Given this list of marker genes SNORD50B, NOP56, POLR1D, RIOX1, HNRNPL, MTERF1, DHX15, KCNC3, TSEN15, CCDC18-AS1, PARVG, RARS1, LINC00635, RPL13, NEAT1, TXNIP, TPM4 (tropomyosin 4), NSA2, PCLAF, ZC3H15, NUP155, MMADHC-DT, SPINT2, CKAP5, HCFC1, RIN1, HSPA8, DR1, ADAT2, LINC00663, CAPN7, UBE2K, SEMA4C, RACGAP1, HAGH, NOTCH1, ZNF25, GZF1, ZSCAN9, PECR, RNFT2, ZNF888-AS1, SYMPK, FBXO4, MAP1LC3B, ELOA-AS1, ADAM15, ZNHIT3, ZNF569, CAPRIN2, ST6GAL1, IGDCC4, HNRNPDL, LINC01719, ENSG00000233461, MAP3K5, CYTH1, HLA-DRA, DEPP1, SLC4A2, FAM167A, C3orf38, FRMD4A, MTRF1, POU2AF1, GAS1RR, ZBTB37, TBC1D19, MALAT1, OASL, PRKAR1A, MIR567, CDKN2D, PIH1D2, LINC01058, SLC3A2, KDM3B, DYNC2H1, APH1A, PPP1R15A, SNORD12C, RHOF, LMBR1, EHD1, RPL39L (ribosomal protein L39 like), EIF5A, MED16, WDR36, CD27, POLR3B, GPRC5B, EIF4ENIF1, GALNT16-AS1, BTG1-DT, ATF3, MBD6, NSFL1C, LY9, DCDC1, CRIPT, INPP4A (inositol polyphosphate-4-phosphatase type I A), ENSG00000282936, SLC30A6, ESYT1, CRK, RUNX3-AS1, CA11, GAPDH, UTP18, SH2D6, TTYH2, MPLKIP, SLC25A23, ENPP3, ARHGAP1, MTF1, NSD3, RBM8A, TMEM242-DT (TMEM242 divergent transcript), SNHG10, HLA-F, RUVBL1-AS1, LIMD2, IL10RB, TPI1P2, C12orf57, CDC42EP4, SLC1A4, PRORSD1P, NAA25, EWSR1, VPS51, ZRANB2-DT, RNF145 (NCBI Gene Id 353159), RPL7L1, HTATSF1P2, SLC37A2, EIF1AD, RNF41, BLK, PCBP2, IRF1, PELP1-DT, PLCXD1, GORASP1, DNAJC2, DIAPH1, NUP54, SLIRP, ADAP2, YIPF2, DLD, HIRA, MTOR (mechanistic target of rapamycin kinase, NCBI Gene Id 2476), TAS2R14, ZSWIM8, ITGB3BP, HSCB, B4GALT4, MTMR2, PPIP5K2, FBXO27, TCF7, TMEM114, CCDC28B, MSL2, TADA2A, CSPP1, KNSTRN, CALCRL, MON1B, MRPS18C, IGFLR1, KGD4, NDUFAF5, MIEF2, ARHGEF2-AS2, MBD1, KPNA6, GLRX, CAMLG, CENPU, KBTBD2, TMBIM1, TLE3, INPPL1, TENT2, ARTN, AFTPH-DT, CENPN-AS1, EGR3, IPO13, TRAF3IP3, GIN1, POLR2A, IMPDH2, SEC22B, MICU1, ITGA1, GTF3C2, BMS1P4-AGAP5, DNAJC24, IPO4, WIPF1, SLC35A3, ANAPC15, TRIP4, SNHG7, SRI, STIM2, MDP1, SLC35B1, TMBIM6, VPS13B-DT, DRG2, FLT3LG, MIR9-2HG, SNX5 (NCBI Gene Id 27131), ATN1 (NCBI Gene Id 1822, atrophin 1), DDIT3, NOSIP, RPS14, SUPT7L, RAPGEF3, CPSF2, PRH1, PARN, RUVBL1, PPP1R21-DT, CLUAP1, LIPE-AS1, LRP4 (LDL receptor related protein 4), ZNFX1, RPL18A, UBE2C, TMEM167B, ARPC5, PTDSS1, PRRG2, ZNF574, ERF, CDK1, SBDS, ZMYM1 (NCBI Gene Id 79830), LINC01275, MIR4434, RBM5, BMS1P4, RPS21-DT, GFM2, DNM2, RNU6-9, LOXL3, SLC2A4 (NCBI Gene Id 6517), LIX1L, SNORD110, ITGA5, CD8A, LYRM1, ZCWPW1, PPP1R21, UQCR11, CXCR4, PNRC2, MYL5, PCNX4-DT, MCEE, ELMO1, SIDT2, MIR638, TRPV2, VPS25, PLEKHG1, ZSCAN16, LSG1, WDPCP, RNA5SP60, BABAM2, NCAPD2, ZFAS1, KCNIP2-AS1 (NCBI Gene Id 100289509), AP4E1, DHX33-DT, TMEM70, GLUD1P3, BCL9L, DGKH, GSTCD, ANKRD34A, TCEA1, TRIM33, POLR1HASP, HOXB5, KLF7, PELP1, SSBP1, MAST3-AS1, TSC22D4, FIS1, NME1, VEGFA, EMC10, CXXC5, IRF2BP1, PLCG2, IGHMBP2, IL10RB-DT, AGRN, MIR6853, ZBTB40, MUS81, MLLT6, KDM4C, FHIP1B, DAPP1, DUS1L, NAA16, KDM2A, SBDSP1, DCUN1D3, IRF9, C1RL, GLIPR1L2, SMG7, ZFP36L1, ANKRD40, PTRH1 (peptidyl-tRNA hydrolase 1 homolog), LY75-CD302, SKIL, ARHGDIA, KDM1A, TMEM230, BRD1, PKIG, TACO1, JUN-DT, STX18-AS1, NUP205, MPHOSPH10, CENPA (NCBI Gene Id 1058), NDUFV1-DT, WDSUB1, SCAP, NUMA1, TMEM14B-DT, BCL2A1, PLXNC1, SIAH1, ENSG00000272008, ZNF331, CCDC144BP, TPT1, SLC44A1 (NCBI Gene Id 63942), PREX1, HAVCR2, SRGAP1, INVS, RNF185, CD86, SNORD35B (NCBI Gene Id 84563), FBXO31, ETFB, CENPT, CCNC, CHD8, AKAP8L, SAMD12-AS1, FUS, TRAK2, BUB1, LTA4H, ZNF425, U2AF2, CLPB, MIR6815, SPRING1, IQCH-AS1, RHOT2, EIF5, PCNX4, SUV39H2, EIF4A1, TOP1, ATMIN, ZFP36, FANCI, SH3BGRL3, NPLOC4, UGGT1, DNAJC25, FBXO34, GRK2, MRPS31P5, GPR156, VPS26B, GNA13, FLYWCH2, TBC1D4, CLTC, NCBP2, OSGEPL1-AS1, JMJD1C, CDKN1B (NCBI Gene Id 1027), TCF4, COA6-AS1, CLK3, KBTBD4, UQCC6, PSMD3, TMEM41B, CHEK2, TMEM187, TLN1, MED15, C1orf54, FBXO28, ZNF408, RANBP2, PTPN11, CPOX, SMARCD2, SLC25A3, IGLV2-5, ICAM1, ZDHHC20, HDAC11, KIAA1671, ATP13A4, ZNF581, BNIP1, BRF2, C2orf92, RBM17, GATC, TOR1AIP1, NCOR1, MIR181A1HG, PBRM1, UBE2I, SMARCA2 (NCBI Gene Id 95083), SMC3, ATG4B, PRR4, IRF2BP2, NPM1, NDUFAF1, DNAJC25-GNG10, FXR1, SATB2 (SATB homeobox 2), ESS2, THUMPD3-AS1, EOGT, POFUT1, GAS1, THOC7, GEMIN5, H3-3B, UBE2L3, CDK6-AS1, QRICH1, GHRHR, SAMM50, CDK11A, CARD19, FUBP1, IKZF4, YWHAG, PEX3, CPED1, RIPK3, POMGNT1, EDC4, STT3A, RUNX3, DUSP10, JUN, UROD (uroporphyrinogen decarboxylase), NOLC1, RRAGA, PUS10, PLAGL2, MIR5708, ALG3, MRPS33, ERI2, PET100, PHF5A, MTERF3, SAXO1, ARF4, FBXO38, EOGT-DT, HSP90AB1, AP4B1, GIHCG, POLD4, DDX18, NEU3, PARG, ZNF25-DT, NKAPD1, WDR74, RN7SL3, DHRS13, ENSG00000255240, H3-3A, ZNF384, RNU2-37P, TRMT5, EIF2S2, CHSY1, MRPL21 (mitochondrial ribosomal protein L21), TIMM29, ATP6V1G2-DDX39B, LY75, XPR1, SULT2B1, POLG, CDK5RAP1, MGC16275 (NCBI Gene Id 85001), RPS4X, LRRC37A5P, HEXIM1, STAT3, DPP8, RBM4, TPP1, CCDC117, SNORA71D, POLR1G, SF3B6, INO80B, MIDEAS, HIVEP1 (HIVEP zinc finger 1), MTMR9, BTN3A2, BRIX1, AAAS, FRA10AC1, TAGLN2, TAF8, TNIP2, RAB1B, GCA, DNAH7, BORCS8, VOPP1, HMGXB4, FAHD1, LDAH, GUCD1, TBC1D10B, FOXJ2, C18orf21, SH3YL1, GOLGA5, POLDIP3, HINT3, PPP2R3B, RGS5, LINC00265, OPA1, ENSG00000183154, EXD2, MED23, ZFYVE1, DHX33, TRUB2, TMEM101, RNA5SP283, BANF1, NFKBIL1, UBE2M, COIL, SEPTIN9, SCAI, TSR1 (NCBI Gene Id 55720), PLEKHB2, MRPS31P4, CDNF, RBM26-AS1, TRAF2, H4C4, BMS1, NR6A1, KIF18A, SNAP25-AS1, YJU2, STRADB, MIAT, DCLRE1B, CSK, ARL8B, ZDHHC2, ITGAL, MRPL16, DNAJB12, NPDC1, XPNPEP1, ZNF610, DNMT1, STK35, TNS2, DPY30, MIR4674, TNPO3, CDC73, GLRX5, IL6ST-DT, UBA7, B2M, UBE3B, RSRC1, CLIP2, SPON2, COQ4, CIB4, EIF3H, ZNF570, BAG6, ZNF580, ZC2HC1A (zinc finger C2HC-type containing 1A), P2RX5, TIMMDC1-DT, CXXC1, LMBR1L, SH3BP5, INO80B-WBP1, ATXN7L3-AS1, TRMT10C, SRPRA, CIITA, ZNF268, ECE1-AS1, R3HCC1, GOSR1, AIF1, ACACA, ANKRD39, DSTYK, GEMIN8, ABHD5, SYNE3-AS1, EML6, GNB2, ATG5, JMJD4, AGAP3, ING1, CFL1, TSPAN10, PDE6D, CALM1, ORMDL2, MBTD1, MRPL51, SGCA, DCP1A, FBXL3, LENG8, HDAC2-AS2, MRPS31, SH3BP1, NR1H2 (nuclear receptor subfamily 1 group H member 2), CHEK1, HSPA14, CCNJL, SLC35A2, SELENOH, EEF1A1P23, TFEB, ESF1, TIMMDC1, IDH2, STXBP1, ZNF827, IRF4, ENOPH1, ZNF165, GFM1, ZBBX, SERBP1, LINC01694, PPP1R3B, KMT2D, WDR83OS, MDH1, CAPS2, STX16 (syntaxin 16), LSR, WDR31, TLR1 (toll like receptor 1), NUP107, PPM1B-DT, SRSF11, PSMF1, TMEM175, ATP6V1G2, BRAF, RNVU1-6, CHIT1, THAP11, SNAP47, RN7SL521P, PATL2, ANK2 (NCBI Gene Id 4028), ZDHHC12-DT, NUP153, MKRN2, MIR17HG, GCC1, TIPARP, RNPC3-DT, MIR7845, ADRM1, SNHG17, RPRD1A (regulation of nuclear pre-mRNA domain containing 1A), AURKAIP1, ZNF20, RAB18, MFGE8, TCP11L2, RNVU1-31 (RNA, variant U1 small nuclear 31), CASP7, TNFRSF13C, RBM3, TATDN3, GTF2H4, MNAT1, ATP13A1, SLC33A1, SPAG8, CHD1L, VAPA, IFI16 (interferon gamma inducible protein 16), ZDHHC8, PIK3R2, TATDN2, YTHDC1, NCAPD3, ADISSP, MLH1, FAAP20, PDCD6-DT, RPS19BP1 (ribosomal protein S19 binding protein 1), FOCAD-AS1, NOL8, BTRC, RBKS, ATXN7L3, CUL2, DUSP11, NFKB2, STK17B, H2AZ1-DT, VPS9D1, EPM2A, KXD1, ENDOG, EEF1G, EEIG2, SLC27A5, MEPCE, RHBDD3, TUT1, CAPRIN1 (cell cycle associated protein 1), COPE, ADNP, EHMT2, KATNB1, PIK3R5-DT (PIK3R5 divergent transcript), DOK3, CD19, COL6A4P1 (collagen type VI alpha 4 pseudogene 1), CNBD2, HUWE1, POLG-DT, IFT56, MGME1, METTL17, LINC02918, YWHAE, TSFM, RBM14, RPL13A, GOLGA3, POLR3GL, PARAIL, CCAR2, KLC1, STAM-DT (STAM divergent transcript), COPS5, RFXANK, SCN4B, PPP1R10, ATP5ME, FYN, THYN1, MTF2, ANAPC2, NLRC5, PITPNM1, RNU6-859P, PARP10, SRGN, C17orf75, LRP3, LRP4-AS1, PGM1 (NCBI Gene Id 5236), SLC2A1, WEE2-AS1, RBM38, PLK3, COQ6, RPL41, ZMYM2, FAM228B, NME1-NME2, TSNAX, SF3A2, APOLD1, MIR3684, TOP3B (NCBI Gene Id 8940), POU6F1, NXT2, CDKL1, RPL29, TLDC2, MRPS12, ZNF778, S1PR2, CARS2, ABRACL, FBXO38-DT, ACKR3, GAS5, SAR1B, CWC25, GIPC2, KLC2-AS2, OSGEPL1, MAPK14, HCG27, CHST12 (NCBI Gene Id 652072), CNTN2, TNRC6A, SUB1, DOK1, F12, CCNA2, LTV1, TSSC4, TRAF4, PARP3, SEPTIN2, SBNO1, UTS2B, BANP, ATP2B4, TDG, UTP3, GIMAP5, COPS7B, ATP2A2, ENSG00000232995, SCAND1, MBTPS1, SNORA44 (NCBI Gene Id 677825), PPP1R26, C1QTNF6, TRIM28, PAXBP1, DDA1, INTS12, TMEM41A, FGR, TLL2, TRMT61A-DT, GPNMB, STAG3 (STAG3 cohesin complex component), CLDND1, CCDC9B (coiled-coil domain containing 9B), NARS2, ARID5A, HDAC2, NDUFB1, PGAP2, APRT, RAPGEF1, CEP57, HINT1, NDUFS3, WDR83 (WD repeat domain 83), VARS2, PDCD7, PDGFRA, AP3M2, ZNF721, FOXM1, ACBD6, ANKRD44, HLA-C, MIR4727, MRPL40, POU2F2, AARS2, ZNF419, SOCS7, BORCS8-MEF2B, NEMF, SMG7-AS1, AP3S2, DTX4, SSNA1 (SS nuclear autoantigen 1), SNORD33, INTS5, EIF3F, NDC1, KANSL3, ELAVL1, DEPDC5, STIM2-AS1, MRPS18B, PHLPP1, SNORD34, KLHDC10, DLG1, SLC39A3, DNAJC7, IRF5, RGL1, HARS1, TRA2B, HNRNPAB, RNVU1-15, NSL1, FBXO17, ANO10, L3MBTL2 (NCBI Gene Id 83746), SLX9, SUGCT, OVCA2, PTCH1, LITATS1 (lncRNA induced by TGF-beta and antagonizes TGF-beta signaling 1), PSMD6, LAS1L, GTF2IP13, VILL, SMG8, CHD2, DUSP7, DPP9, RAB5C, ZNF276, PLAG1, STX16-NPEPL1, SLC12A6, TTC16 (NCBI Gene Id 158248), PES1, ALDOA, RASSF5, TARS2, ZNF747, EPM2AIP1, ZNF554, SARS2, ZNF778-DT, SLC4A1AP, KIAA0753, ITGB7, PPP1R13L, HSP90B1, TUBB, GRK6, UBE2D3, LIX1L-AS1, CBR4-DT, ILK, USP42, PPP1R18, GPANK1, BORA, RPL38, TSR2, TMPO, SGSM2, SF3A3, SLC30A6-DT, RNU7-27P, PDCD6, TUBA1C, MIR3142HG, TET3, NCSTN, FXN, MYCBP2, TXNDC17, IFRD2, RNMT, AQP7, TRDMT1, PDCL3, MIDEAS-AS1, VTA1, SEPTIN7P2 (septin 7 pseudogene 2), LYSET, KLHL20, GTF2I, IGHM, LSM11, TMEM63A, RSPO2, NDUFV1 (NADH:ubiquinone oxidoreductase core subunit V1), ZBED5, RNVU1-14, LINC02901, XAB2, ATXN2L, TRIM25, INTS10, NKAPP1, DDX47, SNRNP27 (NCBI Gene Id 11017), TMEM243, BASP1, THAP4, TUBE1, CIRBP, KRTDAP, KCNN1, FOXRED1, GRIK4 (glutamate ionotropic receptor kainate type subunit 4), DMAP1, PSMC2, NDUFC1, ANKRD23, POM121L2, ZFAND5, ALKBH1, PELO, ZNF337, ZC3H12D, TSNAX-DISC1, ENSG00000223881, MLEC, NLRX1, C19orf48P, MINCR, TVP23B, RAD54L, RDH11, RRP15, PDE4A, ADAM28, WNT10A, RAB35-AS1, FNDC3B, SLC38A2, SNORA61, PLEKHJ1, DNAJB4, CSNK1G3, RNF216, SELENOOLP, AAR2, BTG1, UBE4B, CACNA1A, ZNF56P, ARHGEF1, MRPS23, ZNF747-DT, CGGBP1, SLC39A9, CDK6, ACO2, RSRC2, EZH2, HLA-DQA1, DEF6, GLIS2, ZKSCAN8, FAM229B, CDKN2C, NDUFS6, CRIP3, SEPHS1, PRRT3, NALT1, SNRPB, UTP23, JTB-DT, RAD1, CCND3, AXDND1 (NCBI Gene Id 148436), ABHD16A, SMAD7, MRPL44, MIR3928, ITPRIP, RNF44, NPR1, SGO2, OTUD7B, CENPBD1P, ZBED5-AS1, CNNM4, SNORA48, CENPP, MX1, HELQ, METTL15, HYOU1, ARHGEF2, RAB3D, GNG5, BBS1, SNHG5, ZNF548 (NCBI Gene Id 147694), NUB1, RNPC3, FAM118A, FRG1HP, GBA1, ERGIC1, CSTPP1, CHCHD7, NDRG3, TLCD3B, SNORA51, OGA, GARIN5A, SLC4A5, SUV39H2-DT, NEK4, TEDC1, SERGEF, COPS4, SETD5, C2, ZNF461, ALG10, MRPL11, SNORD32A, TRBV13, EPCIP-AS1, TMEM242, NDUFS7, RRM1, ZNF644, RABEP2, KAT6B, TMEM102, CASTOR3P, SLC38A6, LYRM9, ZNF594-DT, MAN2C1, FLRT3, TEFM, ANKRD11, UBE2H, BCAS2, INO80D, MIR4539, STX18 (NCBI Gene Id 53407), GGA1, COMMD2, GTF3C2-AS2, PIBF1, RELA, SOX2-OT, SET, ALDH5A1, TMEM128, ZBTB4, SNX8, UBE2H-DT, UBE3D, NFE2L1, KCTD10, JPX, RFC3, RBM28, ASB1, RPS7, KDM5C, PKM, EXOSC3, GET1, SFPQ, PIGL, LINC02687, ABCD2, ACAD8, YTHDF3-DT, ARHGDIB, PDSS1, CNNM2, SLC1A5, TMF1, RAVER1, MILR1, RBBP5, IGF2BP3, ZER1, BSCL2, PCDH1, ELOC (elongin C), HDLBP, SMIM12, ISCA2P1, THRA, RIT1, NUP107-DT, HNRNPM, ARHGAP22, RPS9, CREB3, MBTPS2, PITHD1, NUF2, LINC01547, PLEKHM3, OSBPL3, YTHDF3, VPS13B, ABCA11P, here is a description of the gene set: Human Gene Set: WRNIP1_TARGET_GENES Genes containing one or more binding sites for (WRNIP1) in their promoter regions (TSS -1000,+100 bp) as identified by GTRD version 20.06 ChIP-seq harmonization. species: Homo sapiens from publication Yevshin I, Sharipov R, Kolmykov S, Kondrakhin Y, Kolpakov F (PMID 30445619)